The following is a description of a gene set: Any process that regulates the rate, frequency, or extent of gene silencing by RNA. Gene silencing by RNA is the process in which RNA molecules inactivate expression of target genes. species: Homo sapiens Human Gene Set: GOBP_REGULATION_OF_GENE_SILENCING_BY_REGULATORY_NCRNA, and this is the list of marker genes: TRUB1, FMR1, TRIM71, TIAL1, ELOC, LIN28B (lin-28 homolog B), PRKRA, STAT3, LINC-ROR, TP53, ELOB, FXR1, DND1, TENT2, BCDIN3D, HOXB-AS3, ZC3H10, RIPK1, ZSWIM8, BMP4, ADAR, ELAVL1, PUM2, MAEL, PUM1, ZFP36, LIN28A, ZMPSTE24, TARBP2, TGFB1, OIP5-AS1, IL6, DGCR8